The following is a description of a gene set: species: Homo sapiens Human Gene Set: GOBP_NORADRENERGIC_NEURON_DIFFERENTIATION The process in which a relatively unspecialized cell acquires specialized features of an noradrenergic neuron, a neuron that secretes noradrenaline., and this is the list of marker genes: PHOX2B, EDNRA (NCBI Gene Id 1909), SOX4 (SRY-box transcription factor 4), SOX11, PHOX2A, EDN1, HAND2, RNF220, INSM1, ZC4H2, ASCL1